Given this list of marker genes AEBP1, OCM, AMN1, GAS6, FUNDC2 (NCBI Gene Id 65991), TGFBR2 (transforming growth factor beta receptor 2), NNAT, DYSF, here is a description of the gene set: To identify methylation-silenced genes in prostate cancers, a microarray analysis for genes up-regulated by treatment with a demethylating agent, 5-aza-2'-deoxycytidine, was performed using three rat prostate cancer cell lines. Eight genes (Aebp1, Dysf, Gas6, LOC361288, Nnat, Ocm, RGD1308119, and Tgfbr2) were re-expressed at 16-fold or more, and their promoter CpG islands were shown to be densely methylated in the cancer cell lines. From the eight genes, Tgfbr2, a key mediator of transforming growth factor-beta (TGF-beta) signaling that has been strongly implicated in human and rat prostate carcinogenesis, was selected, and its silencing in primary samples was analyzed further. Tgfbr2 was methylated and markedly down-regulated in three of seven 3,2'-dimethyl-4-aminobiphenyl-induced invasive adenocarcinomas in the dorsolateral lobe of the rat prostate. In humans, marked down-regulation of TGFBR2 protein was observed in 12 of 20 high-grade prostatic intraepithelial neoplasia and 36 of 60 prostate cancers. DNA methylation of the human TGFBR2 promoter CpG islands repressed transcription, if present, but neither methylation nor mutation were detected in 27 human prostate cancers analyzed. Methylation silencing of rat Tgfbr2 was associated with histone H3 lysine 9 trimethylation, whereas decreased expression of human TGFBR2 was mainly due to decreased transcription activity, sometimes in concert with histone deacetylation and H3 lysine 27 trimethylation. The identification of methylation silencing of Tgfbr2 in rat prostate cancers, in accordance with TGFBR2 down-regulation in human prostate cancers, will enable us to analyze how aberrant methylation is induced in vivo and identify factors that promote and suppress the induction of aberrant methylation. Human Gene Set: YAMASHITA_SILENCED_BY_METHYLATION studied in species Rattus norvegicus from publication Yamashita S, Takahashi S, McDonell N, Watanabe N, Niwa T, Hosoya K, Tsujino Y, Shirai T, Ushijima T (PMID 18381416) Genes silenced by DNA methylation in prostate cancer cell lines.